The following is a description of a gene set: Human Gene Set: SYATTGTG_UNKNOWN Comprehensive identification of all functional elements encoded in the human genome is a fundamental need in biomedical research. Here, we present a comparative analysis of the human, mouse, rat and dog genomes to create a systematic catalogue of common regulatory motifs in promoters and 3' untranslated regions (3' UTRs). The promoter analysis yields 174 candidate motifs, including most previously known transcription-factor binding sites and 105 new motifs. The 3'-UTR analysis yields 106 motifs likely to be involved in post-transcriptional regulation. Nearly one-half are associated with microRNAs (miRNAs), leading to the discovery of many new miRNA genes and their likely target genes. Our results suggest that previous estimates of the number of human miRNA genes were low, and that miRNAs regulate at least 20% of human genes. The overall results provide a systematic view of gene regulation in the human, which will be refined as additional mammalian genomes become available. Genes having at least one occurrence of the highly conserved motif M71 SYATTGTG in the regions spanning 4 kb centered on their transcription starting sites. The motif does not match any known transcription factor binding site. from publication Xie X, Lu J, Kulbokas EJ, Golub TR, Mootha V, Lindblad-Toh K, Lander ES, Kellis M (PMID 15735639) studied in species Homo sapiens, and this is the list of marker genes: MPPED2, RPL30, CELSR3, NNAT, SEC22A, SMAD1, POFUT1, ANKS1B, AHCYL1, GRIN2B, MCMBP, ETV4 (NCBI Gene Id 2118), ITPR3, OMG, CLU, FEZ1, CSNK2B, PIK3R3, PITX2, MYH2, EIF4G1, SEMA3A, KLF13, NR4A3, NECTIN3, ZNF362, ACTL9, CAMK2A, SKIDA1, SOX4, RSF1, RANBP10, ELOVL5, ORAI3, BCL2L11, UBE2O, YTHDF2, TEX35, ZNF281, LIN28A, HOXA2 (homeobox A2), YWHAZ, ANKHD1-EIF4EBP3, NSD1, NFIB, TOMM40, SRSF6, FSCN3, TFAP4, NOL4L, MYL3, GSX1, HNRNPH1, DDX39B, SGIP1, HSPB2, PLXNC1, TSSK3, ARGLU1, GDPD5, FGF14, NDNF, CGGBP1, PPP2R5C, ASB17, CCNT2, NHSL2, RFX4, EGR3, SIRT6, STARD13, ENSG00000204117, CLEC14A (C-type lectin domain containing 14A), ATE1, ENSG00000255537, REC8, LMF1, ZSWIM9, PAX3, KMT2A, RABAC1 (NCBI Gene Id 10567), PDYN, LMBRD1, CYB5R1, CHD4, FOXP2, OTUB1, CLDN17, ARHGEF19, HOXA7, RNF38, ZNF217, RAB3C, CBLB, OPHN1, CA14, GTSF1L (gametocyte specific factor 1 like), CBX8, IBSP, SCUBE2, SH3TC2, PCDHGC3, LDLRAP1, MYO1C, BRWD3, CFL2, UCN2, TRIM39, MARCHF7 (NCBI Gene Id 64844), CIMIP2A, GRIA3, CCDC140 (CCDC140 long non-coding RNA), TLE3, ARIH1 (NCBI Gene Id 25820), RBM4B, YTHDF3, SPZ1, MAPK10, SLC66A2, TRIB1, RNGTT, EP300, NFIL3, CUX1, DLL1, SPATC1, RASAL2, KIF21A, CA2, ZNF532, ABI1, LINC03122, MAPK6, TAGLN3, HOXC6, SUZ12, ANKHD1, LIG1, ADAM22, CAPRIN1, PCDH8, MTF2, DPYSL3, TONSL (tonsoku like, DNA repair protein), SH3BGRL2, NDST2, MBD5, CHD6, DDX3X, BCL2L1 (BCL2 like 1), PRDM13 (PR/SET domain 13), POLR3E (NCBI Gene Id 55718), PDAP1, ORMDL3, GPM6A, TSNAXIP1, KCNF1, GUCA1A, MB, FMR1, ZNF274, KRT8P41 (keratin 8 pseudogene 41), ZC3H6, IFRD2 (NCBI Gene Id 7866), PLAGL2, PCSK1N, TCF7L1 (NCBI Gene Id 83439), BCL11A, ARHGEF15, TPM3, HCFC2, BOD1, MON1A, NNT, ANP32CP, GPANK1, NUFIP2, LMO3, THAP11, BSN (bassoon presynaptic cytomatrix protein), TMEM178A, ILF3, ILF3-DT, BCL7A, EXT1, HOXC4, PRIMA1, FAM81B, HAPSTR1, OLFML3, BAG5, TNP1, GJC2, TNRC6A, C1orf43, PHLPP1, SEPTIN11, GRIK3, CDC40, COA8, GALC, KRT9, RALYL, CASK, MMP16, ACRV1, RTN1, PLP1, IL1RAPL1, FGF17, LAMA1, DLX1, FOXP1, SLC36A3, AAMDC, STK26, SLITRK4 (NCBI Gene Id 139065), CLDN5, ZNF341, KCNQ1DN, PYGO1, CA3, REST, DNAL1, FRA10AC1, ZC3H18, SUGP1, WASF1, ZNF485, CTNNA2, TSR1, NAT8L, MEIS1, ERG